The following is a description of a gene set: from publication Yevshin I, Sharipov R, Kolmykov S, Kondrakhin Y, Kolpakov F (PMID 30445619) Mouse Gene Set: ELL3_TARGET_GENES studied in species Mus musculus Genes containing one or more binding sites for (Ell3) in their promoter regions (TSS -1000,+100 bp) as identified by GTRD version 20.06 ChIP-seq harmonization., and this is the list of marker genes: Kdm3a, Zfp280d, Pax6, Sh2d6, Pdgfa, Cerkl, Ptk7, Zc3hc1, Tafa3, Tex264, Cacybp, Kmt5c, Cyp4f15, Pde9a, Tlk2, Arsa, Rpap1, Atp6v0c, Thap4, Nbas, Pou3f3, Ubl3, Zfp710, 2010110E17Rik, Chn1, Tbl1x, Fam193a, Narf, Atg4b, Hcfc1, Asb7, Mtf2, Phldb1 (pleckstrin homology like domain, family B, member 1), Foxp4, Mir130a, Mycn, Kdm5c, Rpf2 (NCBI Gene Id 67239), Snora17, Gm20604, Hspa8, Sema6a, Fbxo5, Chrna9, Mir7668, Hoxd11, Rab26os, Gm3716, Cxxc1, Mxd4, Ermard, Cdk5rap2, Gpld1, Cenpo, Camk2b, Usp44, Rpl13a, Zc3h6, Llgl2, Lncenc1, Pcolce, Rnu11, Cyb5d2, Scd1, Gdi1, Shc4, Irag2, Phf21a, Rnf182, Gt(ROSA)26Sor, Tex14, Nfyc, G430095P16Rik (RIKEN cDNA G430095P16 gene), Myo18a, Zftraf1, Prrc2c, H4c4, Dag1, Gm20652, Klf4, Cryz, Sulf2, Pkdcc, Teddm2, Nrep, Tbc1d17, Rprd2, Mlh3, Dlgap3, Cd63, D130052B06Rik, Ripply1, Ctdnep1, Kmt5b, Pagr1a, Galc, Atxn7l3, Phactr2, Tnrc18, E030030I06Rik, Taf6, Gm15417, Gm9530, Castor2, Dppa3, Jph4, 1110019D14Rik, Bnc2, Rpl35a, Mapk8ip2, Morf4l2, Pias1, Prmt5, Tuba1a, Cul9, Klhl14, Oas1g, Hacd2, Tuba1c, Gas1, Snord60, Jade2, Dohh, Grk3, Gse1, Rnf220, Otop1, Vps50, Pex19, Crat, Ccdc68, Zbtb24, 1700028D13Rik, Mpdu1, Gm14393, Zfyve26, En1, Wiz, Kctd1, Zzef1, Tm9sf4, Alg13, Cspp1, Nrf1, 2900052L18Rik, 2410137M14Rik, Dsg2, Nr1h3, Mllt10, Gm8177, Phc1, Rnf145, Ccdc71, Snord49b, Ttll11, Zscan10, Ngfr, Pcf11, 2610037D02Rik, Itm2b, C9orf72, Gemin7, Dhps, H4c1, Ogt, Rsbn1, Abi3, Nfya, Bace1, Rab13, Adgrv1, Celrr, Dbp, Mm2pr, Esrra, Lemd2, Son, Clca1, Itga6, Lamb3, Ssbp3, Slc2a3, Gid8, Odad3, Rbpj, Syndig1, Nudt1, Gm14004, Sox11, Ap3d1, Ndufs4, Slc39a4, Kank2 (KN motif and ankyrin repeat domains 2), Pvt1, Abca8b, Pef1, Fbxo47, Tns1, Ankrd35, Wnt8a, Fpgs, Inpp4b, 1700013A02Rik (RIKEN cDNA 1700013A02 gene), Gngt2, Eapp, Adamts1, Dnmt3l, BC065397, Yars2, Klf16, Etv1, Usp10, Col5a1, Zfp467, Myadml2, Adamts3, N4bp1, Ncoa7, Gm24452, Isca2, Lrtm2 (leucine-rich repeats and transmembrane domains 2), Cmklr2, Zbtb38, Npr3, Rpia, Gtf2h1, Serpine1, 4632427E13Rik, Psmb1, 1110025M09Rik, Dleu2, Miga1, Rara, Mkks, Nr3c1, Shb, H2af-ps2, Sf3b3, Exoc3l, Ankrd55, C2cd2l, 9330185C12Rik, Ptma, Zfp207, Tnk2, G0s2, Atp6v1g2, Creld2, Fzd10os, Src, Etv5, Prepl, Mrpl1, Ccnd1, Zfp617, Rps27, Pspc1, Gm15569, Pmf1, 5930403N24Rik, Nr5a2, Rchy1, Ap2b1, Agfg1, Gtf3c6, Lmna, Tmc8, Socs2, E2f3, Ell, Zfp652os, Szrd1, Hsp90ab1, Cep350, Pik3c3, Prpf38b, Cyyr1, Rcc1l, Tmc6, Tle5, BC043934, Gm25857, Stk32b, Ptk2b, 1700008O03Rik, Pik3r3, Gm16876, Zfp652, Nkiras2, Ephx4, 6430562O15Rik, Slc12a4, Car14, Rbm3os, E130018N17Rik, Psmd7, Arhgap12, Acvr2b, Zcchc24, Gba1, Hnrnph1, Gm12100, Oxsr1, Csrp1, Rragc, Aip, Ttc17, Gm12063, Frzb, Ube4b, Clec12a, Zfp516, Fgd5, Ptbp1, Apoe, G2e3, Elob, Gripap1, Sumo3, Knl1, Cacna2d2, Utp18, Abhd12, Klf13, H3c6, Ccdc171, Cdc14b, Gm3764, Apc, Zfp143, Pbx1, Mymx, Cdh1, Clps, Mrps11, Banp, Cwc27, Maz, Snord3a, Fut9, Ndrg3, Tti2, Tmed10, Itsn2, Dnmt3a, Lgals1, Mpped2, Tceal8, Gm9967, Dync2i2, Srrm4, Lexis1, Pald1, Camkmt, Snrnp35, Atxn2, Nono, Ppp1r21, Tmtc4, Gstt2, Tial1, Pex12, Apela, L3mbtl2, Uncx, 4930556M19Rik, Eif5a, Trmt12, Zfp532, Wdtc1, Rbak (RB-associated KRAB zinc finger), H1f2, Ing4, Slc25a44, Aldh18a1, Pafah1b3, Kdm2a, Dhx30, Marcks, Birc2, Zcchc8, Notch4, Skil, Smc6, Sfswap, Rbm38, Stag2 (STAG2 cohesin complex component), Apbb2, Plxdc2, Ccdc174 (NCBI Gene Id 232236), Srp72, Snhg7os, Gm12522, Ptp4a2, Zfp740, Tead1, Ccdc9b, Aco2, Ralgps2, Midn, Septin7, Mylip, Srsf5, Gm20544, Gm25336, Gm20609, Sp3os, Otulin, Zfp747, Rab34, Lrrc8d, Ackr4, Nbea, Orc4 (origin recognition complex, subunit 4), Zdhhc15, Smad7, Pou3f2, Slx4ip, Xpa, Eral1, Rpl34, Ssr2, Tpd52, Slc39a14, Fgfr1, Mir707, Mdc1, Lmtk3, Impdh2, Ankrd34c, Gm16271, Gmeb1, Usp9x, Ip6k2, Fam13c, Uqcrh, Syne1 (NCBI Gene Id 64009), Srrm4os (serine/arginine repetitive matrix 4, opposite strand), Syn1, Plcxd1, Cdc45, Pcdh1, Utp20, Mc5r, Dnajc7, Nrde2, Tmem131, Sphk2, Gm10129, Rpp30, Padi4, Ttc27, Apol7d (apolipoprotein L 7d), Mir503hg, Rbms1, Il33, Prkcsh, Plekhg5, Mir6352 (NCBI Gene Id 102465180), Uspl1, Dnm2, Cox10, Aldh7a1, 1700019D03Rik, Gm10544, D230022J07Rik, Sass6, Dnajc30, Armcx4, Chtop (chromatin target of PRMT1), Tyw3, Rbm19, Slc44a2, Zfp57, Zbtb4, 1700060O08Rik, Smndc1, Nfe2, Ampd3, Pramel13os, Ensa, Gm20605, Elp5, Zfp952, Raf1, Cxcl11, Pwwp2b, Rpl18, Gm15567, Tmem94, Dtx1, Nectin2, Septin2, Prr11, Rhbdd3, Ncor1, Tnnt1, Klf3, Cep112, Tvp23a, Ik, Zfp37, Manba, Trim33, Inava, Kmt2e, Ewsr1, 4930439D14Rik, Deptor, Rnf26, Fblim1, Cd38, Ube2i, Bmf, Zfp553, Slirp, Gm22788 (NCBI Gene Id 115488989), Phf13, Mkrn1, Galk2, Usp38, Sox2, Prrc2b, Gtf2e1, Gm4117, Crkl, Gm5444 (predicted gene 5444), Bcat2, Hspb1 (heat shock protein 1), Iqcg, Cat, Cic, Elovl6, Naa16, Ubtf, S100pbp, Timm44, Mfsd11, Atp5f1a, Pfkfb2, Frmd4b, Aak1, Git2, Col2a1, Tg, Cox7b, H2ac20, Tbc1d13, Ptpn9, Pdlim1, Exoc4 (exocyst complex component 4), Prpsap1, Gm16170, Bscl2, Smim30, Mdk, Eef2kmt, Cdkn2a, Mreg, Spg11, Gm35986, Enpp4, Zfp763, Gm24432, Sall4, Dab2, Wdr77, Celsr3, Tmem164, Pbld2, Pnpla6, Git1, Rpa2, Bcat1, Eddm13, St3gal2, Srsf1, Mllt6, Rabgap1l (NCBI Gene Id 98656), Runx1t1, Nt5c3, Ndufs7, Atxn7l1, Cops5, Washc4, Kntc1, Anp32a, Smad6, 1700001G11Rik, Tet2, Mus81, Lama5, Dok2, Npm3-ps1, Zbtb17, Gsk3b, Amd1, Vcan, Gm13783, Hsd17b11, Srek1ip1, Entrep3, Ly6e, 4930426D05Rik, Nrxn2, Gm11465, Fuz, Prkci, Mical1, Mir100hg, Eif3f, Pphln1, Enah, Grhl3, Pafah1b1, Mylpf, Khnyn, Ctnnal1, Spta1, Hnrnpd, Ino80b, Mios, Ubiad1, Mir290a, Slc7a7, Ywhaz, AU040320, Fubp3, Anxa11 (NCBI Gene Id 353076), Gm14024, Phf8, Spc24, Tmem203, Fbxl5, Fbxo38, Lrrc41, Rnf5 (ring finger protein 5), Rrm1, Coa4 (NCBI Gene Id 68185), H2bc21, Tsc22d1, Pdss2, Ddx3x, Hinfp, Ppp1r8, Uba3, Slc16a9, Zfp219, Elobl, Slc10a7, Get3, Mir125b-1, Knstrn, C330002G04Rik, Ston1, Zfp747l1, Hps5, Ube2l3, Acin1, Nkx2-2, Nopchap1, Spred3, Zfp182, Srrm2, Gabrb2, Atpaf2, Ppp4r2, Yap1, Ech1, Tob1, Ldha, Lrrtm3, Gm12514 (predicted gene 12514), 1700125H03Rik, Mir3078, Adamts10, Gm38411, Ube2g1, Skor1, Foxn3, Pabpc1, Platr6, Ankrd6, Arl6ip6, Ptf1a, Timp4, Mphosph8, Zfp27, Ccnl1, Cops2, Mir302a, Kmt5a, Shc1, Prr36, Slc25a53, Mrps7, Cdk2ap1rt, Psmb5, Rbbp4, Lhx4, Tor1a, Ehd3, Mir8114, Imp4 (IMP4, U3 small nucleolar ribonucleoprotein), Epb41l5, Tpgs1, Mtcl1, 1700101I11Rik, Cbx7, Cnot11, Lhx1, Smarce1, Gm16505, Tox, Ube2uos, 4930461G14Rik, Prr3, Fbxl18, Cln3, Scp2, Kat6a, Wdr46 (WD repeat domain 46, NCBI Gene Id 98062), Sf3a1, Zbed6, AA474408, Pnisr, Zbtb11, Cluh, Txnip, Mir302b, Gm2541, Yars1, Esp8, Zfp563, Gart, Dcaf12l2, Tgif1, Fam193b, Psrc1, Slc6a16, Btla, Asxl1, 2500004C02Rik, Ubqln2, E2f7, Nucb1, Mir8112, Katnip, Dap3, Gm16233, Esrp1, Gm12980, Rxrb, Agtrap, Scfd1, Gins1, Efcab2, Dpagt1, Bmpr1b, Fbxl20, Racgap1, Ece2, Dynll2, Trim25, Hnrnpul1, B230119M05Rik, Hnrnpl, Atl2 (NCBI Gene Id 70260), Bcl3, Sulf1, Polr1a, 2410021H03Rik, Bltp3b, Gm37359, Ssc4d, Cradd, Cnpy1, Prrc1, Prtg, Mir367, Pcif1, 2010310C07Rik, Med25, Nfkbil1, Tnik, Ncor2, Mrps35, Sirt2, Mir142hg, Gm16069, Ints9, Eci1, Med13l, Hlf (NCBI Gene Id 217082), Rad23a, Oxa1l, Lrrk2, Gm25541 (NCBI Gene Id 115489638), Mcf2l (NCBI Gene Id 338499), Map2k5, Kat7, Bcl9l, Slc6a9, Chd2, Ccdc167, Ska2, Slc43a1, Fam169b, Usp32 (NCBI Gene Id 77025), Pou2f3, Brd2, Pnrc2, Atp13a3, Ttk, Slc4a5, Pipox, Mrpl46, Cecr2, Rorc, 4930449E01Rik, Krt86 (keratin 86), Sfmbt2, Hvcn1, Mov10, Cbln3, Dhx32, H2ac15, Il1rl2, Akip1, Sox30, Pcdhgc4, Syne2, Bloc1s5, Tmem168, R3hdm2, Crmp1, Mir9-3hg, Srsf2, Gatad2a, Dmc1, Neat1, Kif5a, Grcc10, Sema4b, Slc17a5, Irf1, Zbtb40, Rigi, Rarg, Snord118, 1700049E22Rik, Prpf40a, Ppp1r10, Limk1, Dnah14, Upf2, Tsc22d4, Tor3a, Cabp1, Cdin1, Rusc2, Rab28, Mfn1, Mrps10, Trbv12-2, Mir17hg, Pelp1, Ptrhd1, Mlana, Nphs1os, Gm13261, Mir135b, Hdlbp, Caprin1, Thrap3, Zc3h4, Gga3 (NCBI Gene Id 260302), Sh3bgrl, Txndc15, Rfx4, Rps9, Plekha7 (pleckstrin homology domain containing, family A member 7), Kmt2c, Adgra2, Dgke, Lemd1, Cdx1, Cbarp, Psenen, Slk, Clcn2, Trim71, Klhl34, 4933426K07Rik (RIKEN cDNA 4933426K07 gene), Adap2os, Pcbp4, Gpr155, Cdc42bpa, 2410006H16Rik, Il1rapl1, Rdh10, Six5, Atf1, Alg12, Fkbp5, Trp53bp1, Mroh6, Lix1, Lef1, Tsc1, Rgs12, Fzd2, Mrpl36, Deaf1, Gm26632, Ddx50, Peak1, Rps4x, Snord42b, Cacnb3, Uck2, Myo1b, Slc27a2, Sspo, Ahdc1 (AT hook, DNA binding motif, containing 1), Bdnf, Stard6, Rptor, Abcb7, Tfeb, Wapl, Vps35l, Cuedc2, N4bp2l2, Ptprz1, H3f3a, Icam1, Bnip1, Ednrb, Jarid2, D16Ertd472e, Septin9, Gm9017, Osbpl1a, 1700052K11Rik, Large1, Srcap, Abcg2, Acss1, Afg1l, Vbp1, Ntn1, Set, Rpl6, Supt5, Sh3tc1, Tcf7l2, Gm24610, Tgif2, Eif3h, Setdb1, Scd2, Castor1, Adamts6, Gm16041, Phb2, Gadd45g, Smpd3, Gmeb2, Gm17501, A230072E10Rik, Cttn, Cdk12, Evx1os (even skipped homeotic gene 1, opposite strand), Usf1, Ftsj3, Baz1b, Arhgef2, Slc29a3, Zmym3, Glcci1, Cfap53, Hipk4, Macf1 (microtubule-actin crosslinking factor 1), Clic1, Platr22, Mup6, Phlda2, Armcx2, Nars1, Naa15, Gm25894, Prorp (NCBI Gene Id 66132), Poglut1, Gm11729, Mrpl35, Rrp15, Cpsf4l, Ino80d, Ipo8, Tulp1, Mllt3, Alkbh1, Mir124a-1hg, Nodal, 4930481B07Rik, Nfib, Tdh (NCBI Gene Id 58865), Cog4, Sowahb, Gm27042, Agbl5, Dpf1, Atrx, Sp1, Pura, Nr2f6, Wsb2, Mrm2, Smcr8, Slc25a1, Plgrkt, Clk1, Tet3, Cul4b, Epc1 (NCBI Gene Id 77195), 9330136K24Rik, Upp1, Caml, Spry4, Zfa-ps, Hspa9, Gabarapl1, Tmem253, Nrros, Rab30, Nfyc-ps, Pfdn1, Osbpl11, Akt1s1, Zfp764, Adnp, Syncrip, Ggn (gametogenetin), Zbtb8os, 9030622O22Rik, Gm26205, Gm12899, Rrp36, Itpka, Tle6, Mtmr10, Gm15351, Mcts1, Zbtb7b, Serpina3i (serine (or cysteine) peptidase inhibitor, clade A, member 3I), Mir5133, Nrarp, Spred2, Cenpl, Cyp4x1, Ptpa, Ncdn, Cstf2t, Cbx3, Gm29050, H4c3, Mrpl58, Myrf, Papolg, Dpm1, Sbk1, Nid2, Cand2, Dennd2c, Mageb16, Cd37, Smim27, Otx2, Cdk6, Mtln, Zmym2, Rasgrp4, Thra, Acp2, Plec, Mettl3 (methyltransferase 3, N6-adenosine-methyltransferase complex catalytic subunit), Tab1, Rundc3a, Atp2c2, Lefty1 (left right determination factor 1), Abi2, AI480526, Altre, Gm25855, L1td1, Col20a1, Snord49a, Camk2n1, T2, Actr8, Abraxas2, Ube2r2, Wdhd1, Pde4dip, Bcam, Mettl16, Snhg12, Pcbp3, Trim23, Coq8b, Taf8, Abl2, Tgm3, Ppp2ca, Unkl, Tab2, Gjc1, Zc3h11a, Tcea3, Ppp1r12b, Pcdhgc5, Sema4d, Farsa, Mrps18b, Gm26424, Zfp597, Zfp936, Commd4, Nfyb, Epha6, Hnrnpk, Mcmbp, Mapk1, Zbtb8a, Aars2, Irx2, Atp5pb, Rimbp2, Chrd, Mrpl52, Ggt1, Prps2, Smpd5, Zic3, Gm11713, Ptcd2, Gm15441, Fbn2, Cfap44, Fbxo24, 1700011B04Rik, Loxl3, Agpat1, Sdf4, Mff, Gm10433, Calr, Cbl, Sh3bp1, Fam222b, Pnkd, Pip4p2, Chd9, Bud23, Mir1934, Trmt13, Cdk2ap1, Pou2f1, Hepacam2, Slfn9, Map1lc3b, Traf7, Slc6a8, A430035B10Rik, Wrap53, Grm8, A730013G03Rik, Gls (NCBI Gene Id 98298), Arap2, Zfp975, Gm11520, Gm35025, Ppp1r3f, Mir124a-1, Ahi1, Hnrnpa2b1, Txlng, Alkbh8, Crygn, Cep89, Zmynd8, Gm22513, Oplah, 4930577N17Rik, 1700010H22Rik, Ndufb5, Exoc7, Exosc2, Rpl7l1, Kcnh2, Gcnt2, Mir3079, Pde4d, Platr10, Kcnd1, Cst3, Tyro3, Msrb2, Zcchc4, Crct1, Eif4a1, Tollip, Pcyt1b (NCBI Gene Id 236899), Nup50, Fam169a, Vasp, Gatad2b, Gm16201, Rcor2, Kmt2b, Dnajc6, Ndor1, Ccdc162, Mbip, H3c7, Prex2, Fbxo11, Capg, Gli1, Zfp672, Arid3b, A430005L14Rik (NCBI Gene Id 97159), Tmem126b, Mfsd4b5, Gm15627, Gm11627, Sall2, Trappc2b, Rasgrp2, Alg8, Zfp976, Mtx3, Mir3083, Gm16096, Gm12194, Serpinb9b, Gpr19, Ssmem1, Hsd17b14, Shld1, Gm2824 (NCBI Gene Id 432938), Gm16341, Schip1, Ppp3cb, Aamp, Ctdsp2, Ptcd3, Gm2559, Rnf114, Erh, 5730405O15Rik, Gm867, 5330413P13Rik, Tulp4, Gm29340, Hdgf, Ldb1, Mcm5, Khdrbs1, Gtf3c5, Slc25a4, Gtf2i, Ncbp3, Gm2673, Mettl9, Ywhae, Triml2, Maml2, Faim, Irf2bpl, Dcdc2a, Ube2s, Ccdc71l, Kansl2, H2bc15, Prickle1, Rian, Aftph, Slc25a5, Mir1894, Dnajc21 (DnaJ heat shock protein family (Hsp40) member C21), Hoxb3os, Arhgef9, Ankrd37, Eno2, Abcg1, Gm9694, Catsperg1, Npc2, Alg3, Fn1, Izumo2, Noct, Gnl1, Kctd10, Nck2, Gapdh, Speg, Hmx3, Lmf2, Lins1, Tjap1, Abhd10, Cdkn1a, Sms, Herc6, Map2k6, Dcun1d3, Wipf2, Gm2453, Kat6b, Lin28b, Angel2, Rims2, Spp1, En2, Fbxl19, Lrriq4, Slc38a2, Igf2bp1, Zcchc10, 1700057H15Rik, Hdac2, Slc6a7, Dcakd, Lrrn4, Rps24, Tmcc1, Ptpn6, Gm40332, BC051226, Crocc, Ep300, 4930503L19Rik, 4933439C10Rik, Trim13, Plpbp, Scn8a, Fbln1, Dars2, Actr3, Ccnk (NCBI Gene Id 12454), Use1, Plcb3, Cops6, Rassf7, Tnks2, 4930511A02Rik, Mbtd1, Mxi1, Zzz3, Gpx1, Chaserr, Faap20, Plin5, Kdm6a, Ltbp4, Uba2, Ccdc157, Fam168a, Tut4, Pantr1, Armcx1, Sec23b, Foxp2, 2610035F20Rik, Rp2, Gnai2, Ntaq1, Zkscan5, Gm23143, Hoxc13, Ccne1, Cuedc1, Rbm5, Mrps18a, Atf7ip, Fam53b, Sucla2, Casd1, Dmac2, Ndufa2, Setd3, Eno1, Itpr3, Mex3a, Vangl1, Mtus1, Ywhag, Daxx, Tsnaxip1, Rbbp7, Slc13a2, Slc16a13, Sumf1, Iscu, Tcf4, Hnrnpr, Mapk11, Mir6917, Taf5, 5031425E22Rik, Snord13, Erf, Ggnbp1, Niban2, Fancl, Nfe2l1, Nmt1, Nanog, Stk38, Kpna2, Smim43, Rif1, Trip12, Slc46a3, Sh3bp5l, Exd2, Ypel3, Spata31d1b, Scyl3, Sp4, Ate1, Pnrc1, Tmem101, Slc7a3, Tmed9, Glce, Zfp462, Kis2, Mir5125, Nr2f1, Kynu (kynureninase), Dok1, Esrrb, Hes1 (hes family bHLH transcription factor 1), Slc39a7, Rnd2, Ino80dos, Zbtb20, Ap1g1, Myef2, Foxr2, Tmem40, Trp53, Gm14261, Crlf3, Rin1, Zfp687, Gm22973, Pim1, Lrrc34, Foxp1, Fbxo36, Mrps27, Fscn1, Tbc1d9, Mir3569, Trim6, Gen1, Spink10, Tssk6 (NCBI Gene Id 83984), Hoxb7, Nup35 (nucleoporin 35), 2810001G20Rik, Tprn, Fbxo15, Eif2b5, Lrch4, Rab7, Ube2w, Msh6, 4833439L19Rik, Trappc13, Epb41, Pcbp1, Nop58, Mcf2, Mir1893, Nfkbib, Zfp608, Fzd10, Cox8a, Rnf157, Pbx2, Nfia, Tbx3, Cdc14a, Naa60, Eras, Mir128-2, Spcs2-ps, Cep15, Gm27211, Col13a1, Foxh1, Mmp25, Gm25867, Hmgb1, 1110002J07Rik, Irx3, Rpl41, 1600020E01Rik, Hmgxb4, Nhsl1, Zfp764l1, Phyh, Ube3b, Rmi1, Gm24453, Inafm2, Rerg, Thap6, Gm12974, Rragd, Llgl1, Gm13421, Itpk1, Ccl20, A930024E05Rik, Slmap, Spic, Smarca4, Srcin1, Krcc1, Mrpl24, B3gnt7, Snora16a, Kdm2b, Kcna2, Atp5f1d, Znrf1, Khdc4, Vrtn, Zwilch, Nhlrc3, Phc2, B3galt6 (NCBI Gene Id 117592), Phax, Fam110b, BC046401, Kcnc2, Ddx47, Pou5f1, Hoxd3os1, Gm29630, Mon2, Pdgfc, Fundc1, Glul, Mettl22, Gnl3l, Mypop, B4gat1 (beta-1,4-glucuronyltransferase 1), Ints14, 2410017I17Rik, Xkr6, Tgfbr1, Ywhah, Rabl3, Rnu7 (NCBI Gene Id 19866), Kcnh8, Mir8120, Ank3, Mir7660, Med24, Fastk, Hnrnpu, Klk11, Commd9, Car3, Lasp1, Spdye4b, Serbp1, Myo10, Pask, Gm14133, Scgn, Gpatch4, Slc12a2, Tubb5, Snw1, Rac1, B3gnt2, Mkrn3, Bcas1os1, Zic4, Dppa2, Ebi3, Eln, Fat1, Mir6347 (NCBI Gene Id 102465177), Zfp472, Psmc5, Rbm25, Fiz1, Malat1, Rpl23a, Shoc2, Top3a, Mea1, Napepld, Tomm40l, Pglyrp1, Mir302c, Dedd, Mir7229, Pfdn6, Mbd5, Gm25939, Slc3a2, Tead2, Etv4, Hbp1, Camk1d, Dlg3 (NCBI Gene Id 53310), Bbc3, Klhdc8b, Itga5, Foxo4, AW209491, Tbl1xr1, Nufip2, Tmem88, C430039J16Rik, Flicr, Hmbox1, Prr14, Eif5, Mir302d, Neurog3, Spry2, Phf5a, Cnpy4, Hnrnph3, Sntb2, 2810402E24Rik, Numbl, Slc39a9, Cdc42ep5, Chfr, Ap4s1, Snap25, Tbkbp1, Gm19426, Zfp503, Proser1, Mrps15, Septin1, Gm3329, Dcdc2b, Slc29a1, Npm3, Eif4g2, Lin28a, Adam19, Tmem209, Ppp1r7, Cnot2, A430105J06Rik, Tmem80, Ccdc124, Msc, Bbip1, Hectd2os, Sart3, A830031A19Rik, Tle4, Rasgef1b, U2af1l4, Ufd1, Gm26562, Ctbp2, Gm11962, Huwe1, Gid4, Rbm47, Fgfr2, Gm29704, Zfp524, Phyhd1, Eif3e, 2700078F05Rik, Ccdc115, Noxo1, Igf2bp3, Slc7a9, Cass4, Klf6, Ccdc25, Trmt1, Emg1, Gm16046, Usp31, Fxr1, Mad1l1